Given this list of marker genes DIO3, SHISA6, FBLN1, PI15 (NCBI Gene Id 51050), LINC02893, COLGALT2, CCBE1, PTCHD1, PHEX, CLCA4-AS1, FAIM2, LINC01133, CCK, DCN, COL1A2, CACNA1G, EGFL6, DCAF12L1, ARSJ, ISLR, SHISA3, TNXB, COL8A2, LRRK2-DT, LMX1A, ANGPTL1, DIRC1, ACKR4, ENSG00000248540, LVRN, KCNA1, LMO7DN, OSR1, C1R (complement C1r), WNT10B, ASPN, SPON2, MGP, CNTFR, CXCL14, GDF6, B3GALT1-AS1, MFAP5, CBLN3, LINC01684, DNASE1L2, COL1A1, FGF19, C1QTNF12, ITM2A, FGF18, MRC2, KCNIP1-OT1, LINC02364, LINC00645 (long intergenic non-protein coding RNA 645), DPT, SLC28A1, COL12A1, IGFBP6 (insulin like growth factor binding protein 6), TMEM119, FNDC1-AS1, COL3A1, CNTNAP4, CTSK, CILP, RSPO3, COL6A6, CERS3-AS1, PCOLCE, FNDC1, CDH18, SCARA5, TMEM26, POSTN, MAL2-AS1 (NCBI Gene Id 105375726), XPNPEP2, KDELR3, PI16, GREM1, MIR1245A, C1S, ENSG00000228877, ANOS1, FNDC1-IT1, WSCD2, PDGFRL, ITPRID1, LINC01139, SMOC2, OGN, DKK2, SHOX2, RTL3, LUM, ABCC6P1, PLPPR5, PDGFRA, LINC02323, here is a description of the gene set: from publication Cao J, O'Day DR, Pliner HA, Kingsley PD, Deng M, Daza RM, Zager MA, Aldinger KA, Blecher-Gonen R, Zhang F, Spielmann M, Palis J, Doherty D, Steemers FJ, Glass IA, Trapnell C, Shendure J (PMID 33184181) Human Gene Set: DESCARTES_FETAL_MUSCLE_STROMAL_CELLS The gene expression program underlying the specification of human cell types is of fundamental interest. The study authors generated human cell atlases of gene expression and chromatin accessibility in fetal tissues. For gene expression, the study authors applied three-level combinatorial indexing to >110 samples representing 15 organs, ultimately profiling ~4 million single cells. The study authors leveraged the literature and other atlases to identify and annotate hundreds of cell types and subtypes, both within and across tissues. Our analyses focused on organ-specific specializations of broadly distributed cell types (such as blood, endothelial, and epithelial), sites of fetal erythropoiesis (which notably included the adrenal gland), and integration with mouse developmental atlases (such as conserved specification of blood cells). These data represent a rich resource for the exploration of in vivo human gene expression in diverse tissues and cell types. Marker genes curated from the annotated cluster as represented in the Descartes Human Gene Expression During Development database. species: Homo sapiens